The following is a description of a gene set: studied in species Homo sapiens Human Gene Set: GSE29949_CD8_POS_DC_SPLEEN_VS_DC_BRAIN_UP To understand the functional relationship between brain dendritic cells (brain DCs) and other myeloid cells, we compared the gene expression profile of m/chDCs to that of bone marrow monocytes, brain microglia and classical spleen CD8+ and CD8- DCs. In order to obtain enough brain DCs for mRNA extraction, we expanded brain DCs with in vivo Flt3L treatment before purification. Genes up-regulated in dendritic cells: CD8+ spleen versus brain. from publication Anandasabapathy N, Victora GD, Meredith M, Feder R, Dong B, Kluger C, Yao K, Dustin ML, Nussenzweig MC, Steinman RM, Liu K (PMID 21788405), and this is the list of marker genes: TCFL5, MICAL2 (NCBI Gene Id 9645), CCL22, HAGH, SPTSSA, PCSK6, GGH (NCBI Gene Id 8836), HERC3, S100A7, SEPTIN8, RERE (arginine-glutamic acid dipeptide repeats), ZBTB1, CLEC16A, ESPL1, HMGB3P30, IL10RA, IL1R2, BCL2L11, AMPH (amphiphysin), AOAH, SLC25A11, SNAP23, TADA3, RBM14, EPS8, ERC2, PEX3, ANK1, DIXDC1, PLP2, CD5, SUN2, TADA2A, RALB, PNISR, DVL3, MTCP1, LARP7, INSIG2, CTNS, ACTN1, EXOSC9, CCN6, ATP2A3, ZNF3, CGRRF1, COG5, STK25, CLASP1, SAPCD1, SCAP, NKRF, PER2, BCHE, DCK, KIAA0319 (KIAA0319, NCBI Gene Id 9856), FUS (NCBI Gene Id 406232), FLNA, RBM5, RMND5B, ABCC1, SART1, PHF2, KDELR2, MAL, PCBD1, ABLIM1, MAPK1, ARHGAP25, CRADD, OSGEP, BRD3, RRS1, PBX3, LY75, DIDO1, SMAD2, TUBB, KLHL18, UPF1, ADTRP, AHCYL1, SERPINB2, NME3, ALDH9A1, TWIST1, CDC45, SCAF8, KCNJ3, ZNF175 (NCBI Gene Id 7728), IL1RN, SLC39A14, SHMT1, PPIA, MGRN1, TFIP11, BLMH, POLE, TRAF5, TIMELESS, NCOA6, MRPS11, TUBB4A, CENPF, SLC18A2, TRAIP, CHML, TUBB2A, JMJD1C, UFD1, ACSL3, TAF1A, ERCC1, ADM, CLOCK, IGF2BP3, XPNPEP1, SERPINB10, VEGFB, PSD4, SELENOP, NTRK1, DAG1, LRBA, ZNF428, IFFO1, ARHGEF10, ZNF423, SUPT4H1, CCR4, PTK2, GATA3 (GATA binding protein 3), MAF, ASCC2, ATP6V0A2, SLC25A20, WDR37, ATG4A, LPIN2, KLF6, RRAGD, MFN1, CREB1, FKTN, FLOT2, TARBP1, RANBP6, P4HA2, RGS19 (NCBI Gene Id 10287), AZIN1, NUP50, OSBPL8, GTSE1, MEF2A, NME4, PDE3B, REEP5, GNAI2, RBM4B, MAOA, SMCHD1, ACAT2, COL6A3, PPP6C, MKI67, KAT5, SPINT2, GORASP1, MAT2A, CAMKK2 (NCBI Gene Id 121657), SLC5A3, ARHGAP11A, CDC25B, NKG7, RNF11, KYAT3, BYSL (NCBI Gene Id 705), GOLGA8A, MGST3, BMPR2, KCTD17, TBP, PPFIA2, TNFRSF8, ZNF273, BAG6, BET1, NFIL3, FXN, DAPK3, CCNG2, SLC4A2, MMUT, SATB1, SOCS1, ARF3, ACADVL, NAB1